The following is a description of a gene set: Reduced number of intrahepatic bile ducts The presence of reduced numbers of intrahepatic bile duct than normal. Human Gene Set: HP_REDUCED_NUMBER_OF_INTRAHEPATIC_BILE_DUCTS studied in species Homo sapiens, and this is the list of marker genes: LMBRD1, TMEM67, JAG1 (NCBI Gene Id 3715), DCDC2, PEX14